The following is a description of a gene set: from publication Rajapakse VN, Luna A, Yamade M, Loman L, Varma S, Sunshine M, Iorio F, Sousa FG, Elloumi F, Aladjem MI, Thomas A, Sander C, Kohn KW, Benes CH, Garnett M, Reinhold WC, Pommier Y (PMID 30553813) Human Gene Set: KOHN_EMT_EPITHELIAL studied in species Homo sapiens Epithelial phenotype associated genes from an Epithelial-Mesenchymal Transition (EMT) gene set allowing sample stratification into epithelial, mesenchymal, and epithelial-mesenchymal categories initially developed on the NCI-60 cell line collection. Expression-correlated genes were derived from data for the NCI-60 human tumor cell lines, as well as data from the Broad Institute's CCLE cell lines. NCI-60 cell lines that selectively expressed a mutually correlated subset of tight junction genes served as a signature for epithelial-like cancer cells. Those signature cell lines served as a seed to derive other correlated genes, many of which had various other epithelial-related functions. Literature survey yielded molecular interaction and function information about those genes, from which molecular interaction maps were assembled. Many of the genes had epithelial functions unrelated to tight junctions, demonstrating that new function categories were elicited. The most highly correlated genes were implicated in the following epithelial functions: interactions at tight junctions (CLDN7, CLDN4, CLDN3, MARVELD3, MARVELD2, TJP3, CGN, CRB3, LLGL2, EPCAM, LNX1); interactions at adherens junctions (CDH1, ADAP1, CAMSAP3); interactions at desmosomes (PPL, PKP3, JUP); transcription regulation of cell-cell junction complexes (GRHL1 and 2); epithelial RNA splicing regulators (ESRP1 and 2); epithelial vesicle traffic (RAB25, EPN3, GRHL2, EHF, ADAP1, MYO5B); epithelial Ca(+2) signaling (ATP2C2, S100A14, BSPRY); terminal differentiation of epithelial cells (OVOL1 and 2, ST14, PRSS8, SPINT1 and 2); maintenance of apico-basal polarity (RAB25, LLGL2, EPN3)., and this is the list of marker genes: LLGL2, RAB25, ST14, CLDN4, EHF, OVOL1, S100A14, IRF6, ATP2C2, CLDN7, ADAP1, ESRP1, CLDN3, MARVELD2, TJP3, MYO5B, EPN3, PRSS8, MARVELD3, ESRP2, GRHL2, GRHL1